Given this list of marker genes RUFY3, ASRGL1, CDC45, KIF14, CEP85, CDKN3, CBFA2T3, DAPK1, TOP2A, ASPM, RACGAP1, BMAL2, RRM2, YBX1, FADS1, ANOS1, DNMT1, MLLT11, GAB2, NUSAP1, MACROH2A1, KIF20A, AURKA, HELLS, SPAG5 (NCBI Gene Id 10615), FAM153A, DHFR, MZB1, TROAP, GINS1, PRSS8 (serine protease 8), TYMS, PMAIP1, REPIN1, ALDH1B1, CENPF, OIP5, HOXA7, PAK4, FANCL, FAM90A1, GUCY1B1, ADA (NCBI Gene Id 100), SLC16A1, DTL, SMARCD1, CEP55, EPB41L4A-DT, PEX5L, ZWINT, CR2, TNFRSF21, HAUS5, ATN1, SSBP3, BEX3, MOK, S100A13, PTCH2, ELOVL5, FXYD2, TK1, GTF3A, TERT, DDB2, CLIC4, ASAP2, POLA2, PCNA (proliferating cell nuclear antigen), DNTT, TBC1D5, PPP2R3A, KPNA2, CDK3, CHAF1A, CENPN, GPSM2, RAD51AP1, GMNN, FAM216A, RAD51, ESPL1, FANCI, EPB41L2, TUBG1, KCTD3, BAHCC1, GAS6, IFT122, H2AX, PIP5K1B, HHLA1, JCHAIN, NASP, ZNF747, ALDH1A1, ANXA1, NCAPG2, TMPO, CDK2AP1, SOCS2, PLK4, CDC20, RPLP1, CCNB1 (cyclin B1), ASB13, TARP, MUC6, TRIP13, EDDM3A, HOXA9, SCD, BAIAP3, BTG4, PHGDH, DLGAP5, NUDT11, NTRK3, HMGN2, CDCA4, HMMR, CTNNAL1, SLC39A9, GINS3 (GINS complex subunit 3), HCFC1, CD99, ZNF835, RHAG, MYB, TENM4, KIF4A, PCLAF, CYP2E1, EZH2, HMGB3P1 (high mobility group box 3 pseudogene 1), SPAG1, ERI2, MCM6, GUCY1A1, E2F8, STRA6, DONSON, MELK, IGLJ3, PSG7, BCAN, PAICS, MKI67, ZNF395, POLE, CTNND1, NREP, SHQ1, PRKDC, CFAP70, HMGB1, TCEAL9, HJURP, CNTLN, TUBB6, CLDN5, KIF11 (kinesin family member 11), RFC4, CDK1, CKAP5, TXN, PCBD1, NCAPH, SELP, RFC3, RAD54L, H4C3, PAQR4, PTTG1 (NCBI Gene Id 9232), HOXA10, NCR1, ACOT13, NEK2, HMGB2, SMARCA4, KCNE2, FZD6, NCAPG, PSMA6, MAST2, SPHK1, CENPS, NOP56 (NOP56 ribonucleoprotein), BUB1B, CRYGB, CCNB2, DNAJC9, EXO1, NCAPD3, PRC1, TNFAIP2 (TNF alpha induced protein 2), HDLBP, CPLX2, ALDH3B2, here is a description of the gene set: C57Bl/6 wild-type and STAT6 KO mice were used to study PPARg and IL-4 signaling. Bone marrow of 3 mice per group was isolated and differentiated to macrophages with M-CSF (20 ng/ml). 20 ng/ml IL-4 was used to induce alternative macrophage activation and 1 uM Rosiglitazone (RSG) was used to activate PPARg. From each mouse 4 samples were generated: 1. M-CSF, 2. M-CSF+RSG, 3. IL-4 and 4. IL-4+RSG. All compounds were added throughout the whole differentiation process, and frech media was added every other day. Control cells were treated with vehicle (DMSO:ethanol). After 10 days, RNA was isolated and gene expression profiles were analyzed using Mouse Genome 430 2.0 microarrays from Affymetrix. species: Homo sapiens Human Gene Set: GSE25088_WT_VS_STAT6_KO_MACROPHAGE_IL4_STIM_DN from publication Szanto A, Balint BL, Nagy ZS, Barta E, Dezso B, Pap A, Szeles L, Poliska S, Oros M, Evans RM, Barak Y, Schwabe J, Nagy L (PMID 21093321) Genes down-regulated in bone marrow-derived macrophages treated with IL4: wildtype versus STAT6 knockout.